The following is a description of a gene set: Human Gene Set: HP_ABNORMAL_ALVEOLAR_RIDGE_MORPHOLOGY Any abnormality of the alveolar ridges (on the upper or lower jaws). The alveolar ridges contain the sockets (alveoli) of the teeth. species: Homo sapiens Abnormal alveolar ridge morphology, and this is the list of marker genes: CD96, EVC, PDE6D, RBM10, WDR4, C1R, ATP6V1B2, KIF7 (NCBI Gene Id 46), CPLANE1, EVC2, TCTN3, DHCR7, ASXL1, CTSC, ARX, DHCR24, DPH5 (NCBI Gene Id 51611), GJA1, RERE, PIGA, SETBP1, SNRPN, OFD1, TMEM216, GNPTAB, TBC1D24, ANKH, SC5D, FTO, FIG4, DIS3L2, TBX15, C1S, TOPORS (TOP1 binding arginine/serine rich protein, E3 ubiquitin ligase), GNS, VAC14, ZC4H2, TMEM231, BRF1, FAM149B1, SH3BP2, LYST, SH3PXD2B, IRF6, NTRK1, KIAA0753, EIF4A3, ELANE